Given this list of marker genes MVB12B, NTF4, GHRH, EPHA2, CYFIP1, ADAMTS12, ARHGEF7, EPHA6, MIR329-1, SGPL1, AKT2, CD3E (NCBI Gene Id 916), TEK, FAM83B, NAMPT, BCAR1, PIK3CB, PTK2B, TNXB, HSPB1, PDE6H, PDK4, SOS1, RABGEF1, APPL1 (adaptor protein, phosphotyrosine interacting with PH domain and leucine zipper 1), EGFR, BLNK, SOS2, BTC, HIF1A, EIF4EBP2, CD8B, FGFR4, MIR1271, FGF4, CBL, FGF9, MIR638, RARRES2, LEPROTL1, HAP1, CD4, MIR103A1, MMRN2 (NCBI Gene Id 79812), GAB2, NPTN, PDE6G, WNT5A, BAIAP2, FGF18, SPRY1, STAT5B, EPGN, ROBO1, VAV2, FOXC2, LRIT3, PXN, SLC30A10, PIP4K2C, SNX6, PDGFRL, GFRA1, TGFA, ANGPT2, GHSR, FRK, TSC2, SLC39A14, NPR2, MTSS1, MAP2K2, IGFBP1, RHBDF2, TYRO3, CSRP3, MAPK1, CSH2, ITGB1, IRS1, BRAF, DSTYK, HIF1AN, ZBTB7B (zinc finger and BTB domain containing 7B), ITGB3, YES1, DOCK3, PRLR, PGF, MMP9, APLN, CSHL1, ZNF106, DOK3, MIR199A1, TMEM108, ERBB3, FLT3, IRS4, PID1, STMN1, IGF1, MYOC, INS, GH1 (growth hormone 1), AHI1, PAK3, VEGFA, ACP4, FRS3, PRKD2, RASA1, DDR2, EFNA2, ABI1, STUB1, CHN1, CDH3, EPHA7, RHOQ, ADIPOQ, SORL1, ADAMTS3, SORT1, AKT1, PLAUR, CNKSR1, NRG2, IGFBP3, RAF1, PAK1, UBASH3B, COL6A1, COL4A5, SH2B1, MST1R, ZDHHC16, IL12A, CPNE3, GIT1, PDGFRB, EPHB6, PTK2, MERTK, FGF12, SHC1, HGF, GFRA2, OFD1, NRG3, KIT, ITGA5, MIR15B, LONP1, CUL7 (cullin 7), NFATC4, VEGFD, HDAC6, RBPJ, BMP5, ERCC1, NGF, CHURC1, MUC20, TMEM204, BLK, PLCE1, CYFIP2 (cytoplasmic FMR1 interacting protein 2), STXBP4, NTRK2, HHIP, CLASP2, CSPG4, COL4A2, FGFR3, EIF2AK3, NCK2, MIR195, MIR573, IL1R1, DOK2, TRAT1, MYO1E, MVB12A, LGMN, MIR29C, RNF126, DCN, CD63, GIGYF1, GHRHR, GRB7, MIR10B, NKX3-1, VTN, WNT1, ZFAND5 (NCBI Gene Id 7763), VPS25, MIR424, IGFBP2, HRAS, GDNF, RBX1, MIR503, SERPINA12, GP6, LYN, RYK, FBXW7, JAK2, GPLD1, COL4A3, SLC2A8, PRKCD, MMP2, RBM4, JAK3, AQP5-AS1, KALRN, EFNB2, DAB2IP, IRS2, SPRY2, DOK6 (NCBI Gene Id 220164), ZNF592, PDK2, DOK4, C1QTNF12 (NCBI Gene Id 388581), EFNA4, FBXW7-AS1, MVP (major vault protein, NCBI Gene Id 9961), NRTN, SMOC2, ERBB4, IFT80, IL31RA, GPER1, FAM83A, CSH1, SHKBP1, ABL1, HHEX, ARNT, GDF15, PDGFD, WASF1, APC, TRIM72, FASLG, ADAM17, CEACAM1, HNF4A, CDK5R1, FOXC1, CLEC14A, NEU3, CNOT9, HRG, SOCS4, ABL2, DOK1, SOCS1, SPG21, NCL, SH2B2, SS18, SAMD12, MAPKAPK3, FIBP (FGF1 intracellular binding protein), NRG1, ROR2, ALKAL1, MAPKAPK2, NDEL1, MIR296 (NCBI Gene Id 407022), OTX2, PRKD1, RGS14, CUL5, REPS2, VAV1, PDCD6 (NCBI Gene Id 206269), CASP3, PRKCB, CSF1 (colony stimulating factor 1), PIGR, NGFR, FLT4, SH2B3, GPRC5A, MET, PIP4K2A, INSRR, LOX, DUSP3, AGT, GFRA3, TIAM1, FZD4, PTPRE, GPR21, FGF2, MIR107, PIK3R1, GAREM1, IGF2, RHBDF1, FER, SH3TC2, NDRG4, MIR146A, PDGFA, RNF115, NGEF, GSK3B, PIK3CA, FGF8, NEDD9, FGF1, GALNT3, ERFE, GSK3A, CCDC88A (coiled-coil domain containing 88A), STAT3, EXT1, NEDD4, FFAR3 (NCBI Gene Id 2865), RPS6KB2, ADRA2A, MAP2K5, SREBF1, MBD5, F3, SEMA6A, SHC3, EFNB1, SHC2, MIR133A1, C2CD5, PTP4A3, PHIP, VIL1, ESM1, EMILIN1, GFRA4 (GDNF family receptor alpha 4), CD8A, FGF22, FGR, IGFBP4, MIR342, PDGFRA, CTSD, FLRT1, WNT4, COL4A6, MMRN1, TSG101, NRP1, ANGPT1, PTK6 (NCBI Gene Id 5753), FLRT3, MYOCD, FRS2, SMPD3, RALA, EPHA8, MIR221, OGT, F7, VWA2, CASS4, RAPGEF1, PTPN12, PRKAA1, HBEGF (NCBI Gene Id 1839), SPRY3, CRIM1, FGF14, SORBS1, PLEKHA1, APOD, MIR26A1, JCAD, GRB10, ERCC2, CBLB, CSF2RA, CD7, AXL, AFAP1L2, DLL1, DDIT4, FOXO4, XBP1, TXNIP, PTPN2, EFNB3, SNCA, ROS1, CADM4, NDST1, PTPN18, BMP2, GKAP1, TGFB1, PTPN3, CLNK, CBLC, EPN2, MPZL1, SIRT1 (NCBI Gene Id 23411), ARF4, CAV2, ANGPTL1, HGS, NR4A3, ANKS1B, PLAT, NPPA, EFNA5 (NCBI Gene Id 1946), SLC2A4, EPHA3, NR2F2, SMARCC1, PIK3R2, EPHA5, NOG, FGF6, CCN2, COL4A1, STAT5A (signal transducer and activator of transcription 5A), SOCS3, NUS1, PIK3CD, ARID5B, FAM20C, IL1B, NR1H4, AGR2, PTPN11, STAP1, CD2AP, SHISA2, CAMLG, ATXN1, AREG, KLB, TSPAN9, MIR1224, MIR1-1, COL1A1, CSF1R, BDNF, RAB7A, MAPK14, GAB4, CTNNB1 (catenin beta 1), GH2, VPS13A, GREM1, MT3, FGF3, FGFR2, FGFBP1 (NCBI Gene Id 9982), FUT7, FYN, PHF14, VEGFB, INPPL1, NTRK1, EPHB2, AHSG, PLCG1, EFNA3, DBX2, SLC27A4, INPP5K, FGF19, ZGPAT, FGFR1, MTCL2, IGF2R, SOCS2 (NCBI Gene Id 8835), MAPKAP1, ERBB2 (erb-b2 receptor tyrosine kinase 2), HIP1, SYK (spleen associated tyrosine kinase), HIP1R, MSTN, RET, CRIPTO, DGKD, ANKS1A, PRDM14, FGF10, CSRNP1 (NCBI Gene Id 64651), RHOD, LTK, EREG, RALB, RTN4 (NCBI Gene Id 57142), SVEP1, RELA, GIGYF2, ZFYVE27, SHOC2, PRKCQ (NCBI Gene Id 5588), SIK2, PROX1, NCOA5, LRP1, ZFYVE28, SRMS, KL, EPHA4, ZFAND2B, ARHGEF28, NUP62, IFT20, BLVRB, DGKQ, PRKCZ, KANK1, CEP57, FGF7, MIR200C, SHC4, NRP2, SIPA1L1, EFS, TIPARP, FBXW8, KIF16B, HCK, AKT1S1, CRK, SNX5, LEPROT, OSBPL8, BCAR3, PDGFB, ROR1, PRICKLE1, GFRAL, CILP, BDKRB2, GHRL, STAT6, RAPGEF2, PIK3C2A, GRB2, SPRY4, FGF23, PILRB, GAB1, SESN3, PDGFC, SOCS7, WDR54, TBX2, FOXO1, PTGIR, PDPK1, MIR29A, KDR, MUSK, MYO1C, FGF17, STON1, PTPRR, RAB14, EFNA1, IFI6, CREB3L1, MMP14 (NCBI Gene Id 4323), LCK, AR, POLR1G, MIR21, NUCKS1, SRC, FGF21, PIK3R3, THBS1, IQGAP1, EPHA10, LEP, ENPP1, ERRFI1, PPP2R5B, IL12B, FLT1, NTF3, RAC1, ADGRA2, SHCBP1, INSR, TIE1, ARTN, SOCS5, NDN, EPHB3, FGF5, EPHB4, LRIG2, AP3S1, SH2D6, MIR149, RUNX2, DOK5, AGTR2, IGFBP5, ADGRG1, TRADD, ALKAL2, MZB1, NCK1, MAP2K1, GHR, PAK2, FSTL4, IDE, IGF1R, ALK, FSHR, MIR16-1, GPC1, NTRK3, ADIPOR1, IGFBP6, PTPN1, FLRT2, FGFBP3, JAK1, GRB14, PIP4K2B, PSPN, NHERF1, ERBIN, TRIM71, NRG4, MTOR, SAMD10, TRIB3, DNAI1, MIR519D, GATA3, CRKL, SULF2, PTPRG, FGFRL1 (fibroblast growth factor receptor like 1), LCP2, MIR10A, TYK2, TNS2, PLCB1, PTPRJ, EPHB1, FGF20, SH3GL2, TSPAN32, RPS6KB1, ZDHHC17, CDH13, EFEMP1, SLC31A1, CHMP6, ITGA1 (NCBI Gene Id 3672), DDR1, FGF16, EGF, PTPRT, CCBE1, SOX9, MYORG, NRXN1, VEGFC, MAPK3, EPHA1, SULF1, FUZ, here is a description of the gene set: species: Homo sapiens Human Gene Set: GOBP_CELL_SURFACE_RECEPTOR_PROTEIN_TYROSINE_KINASE_SIGNALING_PATHWAY The series of molecular signals initiated by an extracellular ligand binding to a receptor on the surface of the target cell where the receptor possesses tyrosine kinase activity, and ending with the regulation of a downstream cellular process, e.g. transcription.